Given this list of marker genes Mad2l1bp, Mir124a-1, Cdkn1b, Npm2, Birc5, Cdc14b, Cdca5, Rgcc, Cdc14a, Tgfb1, Cdkn1c, Mir124a-2, Phb2, Zw10, Ube2c, Mir124a-3, Neurog1, here is a description of the gene set: studied in species Mus musculus Mouse Gene Set: GOBP_REGULATION_OF_EXIT_FROM_MITOSIS Any process involved in the progression from anaphase/telophase to G1 that is associated with a conversion from high to low mitotic CDK activity.